Given this list of marker genes EPRS1, GSPT2, APBA3, EGLN1, CXCL2, CXCL6, ASCC2, SLC20A1, NAIP, CEBPB, RABGEF1 (RAB guanine nucleotide exchange factor 1), ATF4, AKAP12, RND3, HERPUD1, EGLN3, RAPGEF2, NFIL3, FST, IL6, SLPI, PGM1, SPAG9, CH25H, CLEC4E, LCP1, ADM, AMOTL2, THBD, DHRS9, GADD45A, PDLIM5, PPP1R15A, SLC7A11, here is a description of the gene set: species: Mus musculus The ternary complex factor Net/Elk3 is downregulated in hypoxia and participates in the induction by hypoxia of several genes, including c-fos, vascular endothelial growth factor and egr-1. However, the global role of Net in hypoxia remains to be elucidated. We have identified, in a large-scale analysis of RNA expression using microarrays, more than genes that are regulated by Net in hypoxia. In order to gain insights into the role of Net in hypoxia, we have analysed in parallel the genes regulated by HIF-1alpha, the classical factor involved in the response to hypoxia. We identified about genes that are regulated by HIF-1alpha in hypoxia. Surprisingly, when we compare the genes induced by hypoxia that require either Net or HIF-1alpha, the majority are the same (75%), suggesting that the functions of both factors are closely linked. Interestingly, in hypoxia, Net regulates the expression of several genes known to control HIF-1alpha stability, including PHD2, PHD3 and Siah2, suggesting that Net regulates the stability of HIF-1alpha. We found that inhibition of Net by RNAi leads to decreased HIF-1alpha expression at the protein level in hypoxia. These results indicate that Net participates in the transcriptional response to hypoxia by regulation of HIF-1alpha protein stability. Genes specifically up-regulated in SEND cells (skin endothelium) at hypoxia after knockdown of ELK3 by RNAi. from publication Gross C, Dubois-Pot H, Wasylyk B (PMID 17704799) Human Gene Set: GROSS_HYPOXIA_VIA_ELK3_ONLY_UP